Given this list of marker genes IGLV2-11, IGLC2, IGLV1-44 (immunoglobulin lambda variable 1-44), IGKV1D-12, MSR1, CALR, IGKV2D-30, IGLV3-27, IGHV3-53, IGKV3-11, IGLV6-57, IGHV4-39, STAB1 (stabilin 1), IGLV3-1, SSC5D, APOE, IGHA2, HP, COL3A1, APOB, IGHV3-7, LRP1, FTH1, HBA1, HBB, IGHV3-13, IGHV3-11, IGHA1, HSP90B1, MASP1, HBA2, IGHV3-48, IGLV3-19, COLEC11, IGKV1-12, IGHV3-33, IGKV4-1, IGHV2-5, IGLV3-25, IGHV2-70, COLEC12, IGLV1-47, IGKV2-28, IGKV3-20, COL4A1, IGKV1D-16, SCARF1, COL1A1, IGHV1-46, IGLV2-23, SCARB1, IGLV1-40, JCHAIN, HPX, HYOU1, IGKV1-16, MARCO, AMBP, APOL1, SCARA5, IGKV1-5, STAB2, IGKV1-33, IGKV1D-33, HPR, IGKV1-17, IGLV2-8, APOA1, IGHV4-34 (NCBI Gene Id 28395), IGLV1-51, SCGB3A2, IGLV7-43, IGHV3-30, IGKV2-30, HSPH1, CD36, IGHV1-69, COL1A2, IGKV3D-20, COL4A2, IGKV2D-40, CD163, IGKV1D-39, IGHV1-2, IGLV2-14, ALB, IGLV3-21, IGLC3, IGKV5-2, IGKV3-15, SPARC, HSP90AA1, SAA1, IGKV1-39, FTL, IGHV4-59, IGKV2D-28, IGHV3-23, here is a description of the gene set: Binding and Uptake of Ligands by Scavenger Receptors studied in species Homo sapiens Human Gene Set: REACTOME_BINDING_AND_UPTAKE_OF_LIGANDS_BY_SCAVENGER_RECEPTORS